Given this list of marker genes IL1RAP, FBN2, TYW1, ARHGEF38, PLN, EXOC4, SRPK2, TMEM225B, SIT1, STON2, ADAT1, JAG1, METAP2, MRAS, DTL, GANC, ANO10, ADAMTSL4, CPD, SPMAP2, COPS6, NFE2L2, CAPN15, PDE1C, ALDH1A2, SHPRH, IRF6, RAB24, SUFU, FRAS1, CPEB1, ARMC8, KLHL12 (kelch like family member 12), HOXD8, CNOT2, STARD7, CXCL14, RUNX1T1, PCSK7 (NCBI Gene Id 95070), DUSP22, PPARGC1A, THADA, SMARCC1, FMOD, SRGAP1, FGFR1, CAV1, HSPA4, GPR3, RNF170, CCDC6, CLMN, SLC5A7, DOK6, RABGGTB, CORO1C, TRIM66, CD36 (CD36 molecule (CD36 blood group)), OSTM1, RETREG3, PGK1, PRDM2, DDX60L, CASTOR3P, GLCE, NUFIP2, KLRG1, ADRA2B, ACAA2, LIMCH1, HID1 (NCBI Gene Id 80791), CXADR, ZCCHC4, SYNPO2, here is a description of the gene set: from publication Chen Y, Wang X (PMID 31504780) Human Gene Set: MIR6854_5P studied in species Homo sapiens Genes predicted to be targets of miRBase v22 microRNA hsa-miR-6854-5p in miRDB v6.0 with MirTarget v4 prediction scores > 80 (high confidence targets).